Given this list of marker genes CIDEC, HSD17B13, CIDEA, FITM1, FITM2, HILPDA (NCBI Gene Id 92496), here is a description of the gene set: Lipid particle organization species: Homo sapiens Human Gene Set: REACTOME_LIPID_PARTICLE_ORGANIZATION